Given this list of marker genes MYLK, LMNA, MYH11, AP1S1, ACTG2, GATA6, LMOD1, SOX10, GUCY2C, ZMPSTE24, here is a description of the gene set: species: Homo sapiens A colon of abnormally small caliber. Microcolon Human Gene Set: HP_MICROCOLON